The following is a description of a gene set: Genes down-regulated in peripheral blood mononuclear cell responders vs nonresponders in adults (55-64) after exposure to Fluarix, time point 0D. Comment: Gene expression related to HAI response species: Homo sapiens from publication Ovsyannikova IG, Oberg AL, Kennedy RB, Zimmermann MT, Haralambieva IH, Goergen KM, Grill DE, Poland GA (PMID 27441275) Human Gene Set: OVSYANNIKOVA_PBMC_FLUARIX_AGE_55_64YO_RESPONDERS_VS_NONRESPONDERS_0DY_DN To assess gene signatures related to humoral response among healthy older subjects following seasonal influenza vaccination, we studied 94 healthy adults (50-74 years old) who received one documented dose of licensed trivalent influenza vaccine containing the A/California/7/2009 (H1N1)-like virus strain. Influenza-specific antibody (HAI) titer in serum samples and next-generation sequencing on PBMCs were performed using blood samples collected prior to (Day 0) and at two timepoints after (Days 3 and 28) vaccination. We identified a number of uncharacterized genes (ZNF300, NUP1333, KLK1 and others) and confirmed previous studies demonstrating specific genes/genesets that are important mediators of host immune responses and that displayed associations with antibody response to influenza A/H1N1 vaccine. These included interferon-regulatory transcription factors (IRF1/IRF2/IRF6/IRF7/IRF9), chemokine/chemokine receptors (CCR5/CCR9/CCL5), cytokine/cytokine receptors (IFNG/IL10RA/TNFRSF1A), protein kinases (MAP2K4/MAPK3), growth factor receptor (TGFBR1). The identification of gene signatures associated with antibody response represents an early stage in the science for which further research is needed. Such research may assist in the design of better vaccines to facilitate improved defenses against new influenza virus strains, as well as better understanding the genetic drivers of immune responses., and this is the list of marker genes: SPIRE1, SHISA4, HPRT1, DUSP18, SFXN3, ZFAND6, ISL2, GET3, FBXL18, TMED5, PCBD1, MIA2-AS1, RDX (NCBI Gene Id 5962), TNNT1, SLC66A3, AP3S1, INIP